The following is a description of a gene set: Any process that modulates the establishment or extent of the mitochondrial membrane potential, the electric potential existing across the mitochondrial membrane arising from charges in the membrane itself and from the charges present in the media on either side of the membrane. Mouse Gene Set: GOBP_REGULATION_OF_MITOCHONDRIAL_MEMBRANE_POTENTIAL studied in species Mus musculus, and this is the list of marker genes: Mul1, Ppif, Cck, Mapt, Mir451a, Dynll1, Sod1, Trpv1, Bnip3, Pank2, Slc4a11, Hnf1a, Spart, Col6a1, Ndufs1, Ndufs4, Rack1, Mtch2, Bid, Myc, Bcl2, Prdx3, Mfn1, Sod2, Arl6ip5, Ubb, Lrrk2, Bak1, Kdr, Src, Mllt11, Prelid1, Ngfr, Got1, Tmem135, Adcy10, Adora2a (adenosine A2a receptor), Park7, Prkn, Casp1, Kcnq3, Smad3, Oga, Pycr1 (NCBI Gene Id 209027), Mtln, Tspo, Ccn6, Bcl2l1, Pink1, Bnip3l, Ppa2, Abcd1, Ctns, Prkce, Pip5kl1, Slc25a33, Slc25a27, Tspan4, Bok, P2rx7, Bad, Vcp, Bco2, Mfn2, Alb, Stox1, Rnf122, Gsk3b, Tspan9, Mir451b, Cdkn2a, Ndufc2, Ndufs6, Oprd1, Kcnq2, Clic1, Atp5if1, Pmaip1, Ucp2 (NCBI Gene Id 22228), Tusc2, Hsh2d, Lipa, Rbfox2, Akt1, Slc25a36, Ppp2r3c, Gclm, Dcn, Pid1, Gclc, Parp1, Nnt, Bax (NCBI Gene Id 12028), Fzd9, Myoc, Alox12